The following is a description of a gene set: studied in species Homo sapiens from publication Chen Y, Wang X (PMID 31504780) Human Gene Set: MIR9900 Genes predicted to be targets of miRBase v22 microRNA hsa-miR-9900 in miRDB v6.0 with MirTarget v4 prediction scores > 80 (high confidence targets)., and this is the list of marker genes: DESI2, TRPC5, ATP11B, NOL3, ZC3H11A, NR3C2, NFIL3, ADGRL3, NPTX1, RRAGC, ST6GALNAC5, DERL1, SCX, GABRA2, RAPGEF1, CSF1, CERK, UBN2 (ubinuclein 2), GPR55, RPL17-C18orf32, SLC25A38, HOXC6, ALDOB, PRRG4, C18orf32, RPL28, RGS3, CCDC150, CDC42SE2, PPP4R1, FGFR3, NLRP2B, NUAK1, COG5, ZC3H11C (zinc finger CCCH-type containing 11C), CNOT6L, TYW3, KCNQ2, ZC3HC1, PMPCB, RALGPS1, NCBP3, SMLR1, KDM7A, STX3